Given this list of marker genes MIR143, MIR145, DNMT1, MIR199B, MYOCD, FGF9 (fibroblast growth factor 9), here is a description of the gene set: Human Gene Set: GOBP_REGULATION_OF_PHENOTYPIC_SWITCHING species: Homo sapiens Any process that modulates the frequency, rate or extent of phenotypic switching.